The following is a description of a gene set: Mouse Gene Set: GOMF_FILAMIN_BINDING Binding to a filamin, any member of a family of high molecular mass cytoskeletal proteins that crosslink actin filaments to form networks and stress fibers. Filamins contain an amino-terminal alpha-actinin-like actin binding domain, which is followed by a rod-domain composed of 4 to 24 100-residue repetitive segments including a carboxy-terminal dimerization domain. species: Mus musculus, and this is the list of marker genes: Smad4, Rflna, Pdlim2, Tmem67, Dpysl3, Hspb7, Ceacam1, Fblim1, Ceacam2, Crmp1, Rflnb, Dpysl4, Micall2 (MICAL-like 2), Synpo2, Nebl, Xirp1